The following is a description of a gene set: Genes predicted to be targets of miRBase v22 microRNA mmu_miR_7239_3p in miRDB v6.0 with MirTarget v4 prediction scores > 80 (high confidence targets). species: Mus musculus Mouse Gene Set: MIR_7239_3P from publication Chen Y, Wang X (PMID 31504780), and this is the list of marker genes: Rnf166, Akap12, Scyl1, Gmeb2, Lifr, Mfsd8, Zwilch, Sort1, Kcnj3, Mapt, Ccdc120, Pax1, Pde2a, Htt, H2bc6, Ncf1, Frrs1l, Rassf1, Apol6, Hibadh, Necap1, 6430548M08Rik, Cog2, Zmiz1, Phospho1, Arfip2, Fgd4, Apc2, Hmgcr, Sema5a, Rab43, Txn2, Tyr, Gng7, Zyx, Lrrtm2, Tspan11 (tetraspanin 11), Ttc5, Adgrf1, Rrp1, Exd2, Heyl, Adam12, Fbxo46, Impa2, Chrnb2, Hsd17b6, St6galnac1 (NCBI Gene Id 20445), Twf1, Rab27a, Sec24c, Bmal1, Bet1l, Sptbn4, Kcna6, Haspin, Dlgap1 (NCBI Gene Id 71192), Plcxd1, Sncb, Col9a2, Trabd2b, Rph3a (rabphilin 3A), Dsg2, Laptm4b, Sdc2, Ncl, Gpr17, Ak3, Dnmt3b, Slc25a53, Phf20, Git1, Dgkg, Ephb2, Arhgef18, Spmip4, Wdr20, Adra1a, Gucy2f, St3gal1, A3galt2, Ttc23, Slc9a8, Sephs2, Slc6a1, Wsb1, Zswim6, Atp2b2, Syt2 (synaptotagmin II), Tbc1d5, Bclaf1, Phldb1, Arc, Crppa, Clcn5, Adcy1, Kctd5, Ahdc1, Myo18b, Card14, Sftpb, Hic2, Znhit6, Suv39h1, Usp54, Cdk5r1, H2bw2 (H2B.W histone 2), Ankrd54, Tnip1, Pnkd, Morc2a, Ngfr, E2f4, Mtmr2 (NCBI Gene Id 77116), Wdr59, Tyw3, Iqsec3, Slc25a34, Gpatch8, Egr1, Actr1b, Phtf2, Ireb2, Dtx4, Kcnb1, Scn8a, Bcl2l2, Piga, Scp2, Rnf122, AI661453, Mllt1, Zkscan17, Grk5, Ntrk2 (NCBI Gene Id 77471), Qrich1, Paqr4, Ptges, Bank1, Sertad4, Map2k1, Rasal1, Sec14l3, Dyrk1a, Tbc1d2, Dixdc1, Ubtd2, Ube2h, Cdr2l, Clk3, Nsmaf, Gdi2, Itpr1, Srpra, Slco3a1, Tsc22d2, Pacs2, Tnip2, Pex11g